Given this list of marker genes Pmaip1, here is a description of the gene set: electronically inferred by orthology from the curated human pathway species: Mus musculus part of: Activation of BH3-only proteins Reactome Pathway: Activation of NOXA and translocation to mitochondria This event has been computationally inferred from an event that has been demonstrated in another species.<p>The inference is based on the homology mapping from PANTHER. Briefly, reactions for which all involved PhysicalEntities (in input, output and catalyst) have a mapped orthologue/paralogue (for complexes at least 75% of components must have a mapping) are inferred to the other species.